Given this list of marker genes H2BC26, H2AC7, H2BC12, H2AC6, H2AC4 (NCBI Gene Id 8335), H2BC17, H2BC21, H2BC5, H2BC13, H2AX, H2AB1, H4C1, H2BC9, KLK3, H2AC14, H2AC18, H2BC3, AR, H2AJ, PKN1, H2AZ2, H3C1, KLK2, H2BC11, NCOA2, H2BC4, H2AC20, H2BC1, H2BC12L, H2BC14, H3-3A, H3C15, H2BC15, KDM1A, KDM4C (NCBI Gene Id 23081), here is a description of the gene set: part of: RHO GTPases activate PKNs species: Homo sapiens Reactome Pathway: Activated PKN1 stimulates transcription of AR (androgen receptor) regulated genes KLK2 and KLK3 PKN1, activated by phosphorylation at threonine T774, binds activated AR (androgen receptor) and promotes transcription from AR-regulated promoters. On one hand, phosphorylated PKN1 promotes the formation of a functional complex of AR with the transcriptional coactivator NCOA2 (TIF2). On the other hand, binding of phosphorylated PKN1, in complex with the activated AR, to androgen-reponsive promoters of KLK2 and KLK3 (PSA) genes, leads to PKN1-mediated histone phosphorylation. PKN1-phosphorylated histones recruit histone demethylases KDM4C (JMJD2C) and KDM1A (LSD1), and the ensuing demethylation of histones associated with the promoter regions of KLK2 and KLK3 genes increases their transcription.